The following is a description of a gene set: species: Homo sapiens Reactome Pathway: mitochondrial fatty acid beta-oxidation of unsaturated fatty acids The complete beta-oxidation spiral produces and consumes intermediates with a trans configuration. Mitochondrial beta-oxidation of unsaturated fatty acids leads to intermediates not compatible with the four enzymatic steps responsible for the beta-oxidation of saturated fatty acids. Unsaturated fatty acids that have bonds in the cis configuration require three separate enzymatic steps to prepare these molecules for the beta-oxidation pathway. The further processing of these intermediates requires additional enzymes, depending on the position of the double bonds in the original fatty acids. Described here is the beta-oxidation of linoleoyl-CoA. part of: Mitochondrial Fatty Acid Beta-Oxidation, and this is the list of marker genes: HADHA, DECR1, HADHB, ECI1 (enoyl-CoA delta isomerase 1), ACADM, ACADL